Given this list of marker genes mt-Tl2, mt-Tr, mt-Tw, mt-Tf, mt-Tc, mt-Tp, mt-Ts2, mt-Ti, mt-Ty, mt-Td, mt-Ts1, mt-Tl1, mt-Te, mt-Tk, mt-Ta, mt-Tn, mt-Tv, mt-Tq, mt-Tg, mt-Th, mt-Tm, mt-Tt, here is a description of the gene set: The codon binding activity of a tRNA that positions an activated amino acid, mediating its insertion at the correct point in the sequence of a nascent polypeptide chain during protein synthesis. Mouse Gene Set: GOMF_TRIPLET_CODON_AMINO_ACID_ADAPTOR_ACTIVITY species: Mus musculus